Given this list of marker genes Mbd1 (methyl-CpG binding domain protein 1), Sin3a, Sumo1, Pcgf2, Npm1, Ring1, Zfp131, Cbx8, Phc1, Daxx, Park7, Bmi1, Scmh1, Cbx2, Ep300, Ing2, Pias4, Ncoa1, Cbx4, Mrtfa, here is a description of the gene set: electronically inferred by orthology from the curated human pathway This event has been computationally inferred from an event that has been demonstrated in another species.<p>The inference is based on the homology mapping from PANTHER. Briefly, reactions for which all involved PhysicalEntities (in input, output and catalyst) have a mapped orthologue/paralogue (for complexes at least 75% of components must have a mapping) are inferred to the other species. Reactome Pathway: SUMOylation of transcription cofactors studied in species Mus musculus part of: SUMO E3 ligases SUMOylate target proteins